Given this list of marker genes MINDY3, PLCB4, ASCC2, SPNS1, AGPAT1, SHMT1, UBE2D2, MFNG, COL9A3, TTLL10 (NCBI Gene Id 254173), RHOBTB1, TOX2, CHMP1A, PHF21B, CD2, ELMOD1, PCSK1, AMTN, ZSCAN12, NCLN, TAL1, PRR18, GPX5, DCDC2C (doublecortin domain containing 2C), CMPK2, CSRP3, DUSP6, ADGRB1, HNRNPM, DMAC2, NLE1, TCEA3, TRIM14, DPH2, ZIC3, CHIA, KIAA1191, LPCAT2, CD27, FOXC1, LGALS4, GSTO1, NFKBIB, SPAG4, NIPAL3, FRMD8, RNF25, PHYHD1, SEPTIN14, SHC2, MYH3, GATA3, EMG1, MRC1, HES6 (NCBI Gene Id 94875), FTL, AGRN, WDR55, TFF2, NYX, SLC37A2, LY86, CDHR1, HPS4, TNFRSF9, PLK3, NCF2, LAG3, TMUB2, TPSB2, ERAS, C19orf38, NLRP5, MFAP4, NPY5R, CERS2, TMPRSS13, NEDD4, EEF1E1, COL11A2, ZNF48, MED10, ETV5, TFEC, MTARC1 (NCBI Gene Id 64757), FAM3A (FAM3 metabolism regulating signaling molecule A), GATA2, ELF4, PDGFA, NLGN1, LRRC75B, ZNF653, KRTAP4-6, SLC52A2, ADAMTSL4, CD8B, DGAT1, ENG, SIX6, CRISP3, CCER1, RSAD2, AFAP1L1, XAF1, CCDC185, DHX58, PSTPIP2, ZNF654, ULK4, PGLYRP1, PPP1R37, IRAK2, FAM110B, RITA1, MAPK11, TOB2, SH3GL2, AKT1S1, PALLD, CFAP65, ALOX15B, ISCU, PMP2, GFPT2, SSUH2, SH3BP2, FMOD, RRAGD, YJEFN3, ARHGAP26, DDA1, SNX5, NFE2, MYO1D, SUSD6, MX1, GDAP1L1, RND2, ZC3H3 (NCBI Gene Id 23144), COL20A1, ARSK, CTRL, SLC27A1, TMEM30A-DT, BPIFC, NTSR2, P2RX4, MB, LYZL1, SIRT2, OTULIN, TUBA8, RND3, TXNDC2, STXBP3, MOCOS, RFX3, MUSTN1, BOC, KRT24, RGS10, EPX, TRIM59, AMHR2, KCNH7, CTNND1, KDF1 (keratinocyte differentiation factor 1), SRFBP1, KIAA1217, FAM120A, LDB3, ALG5, DAZ2, GFI1, ITGAM, SRPX2, ARAP3, SLC7A8, CIDEC, IFITM3, DPYSL3, CLEC4E, RGR, FGL1 (fibrinogen like 1), IGSF23, KIF21B, ZC3H4, KATNA1, IRAG2, ADAMTS1, MAP3K8, SIPA1, RNF166, BHLHE40, ERP27, CTSG, FBXO31, LTB4R, PPARD, HMX2, here is a description of the gene set: Human Gene Set: GSE22935_UNSTIM_VS_24H_MBOVIS_BCG_STIM_MYD88_KO_MACROPHAGE_DN from publication Qualls JE, Neale G, Smith AM, Koo MS, DeFreitas AA, Zhang H, Kaplan G, Watowich SS, Murray PJ (PMID 20716764) Nitric oxide (NO) produced by macrophages (MØs) is toxic to both host tissues and invading pathogens and its regulation is therefore essential to suppress host cytotoxicity. MØ arginase 1 (Arg1) inhibits NO production by competing with NO synthases for arginine, the common substrate of NO synthases and arginases. Two signal transduction pathways control Arg1 expression in MØs. First, a MyD88-dependent pathway induces Arg1 in intracellular infections, while a second Stat6-dependent pathway is required for Arg1 expression in alternativelyactivated MØs. We found that mycobacteria-infected MØs produce soluble factors that induce Arg1 in an autocrine-paracrine manner via Stat3. We identify these factors as IL-6, IL-10 and GCSF. We further establish that Arg1 expression is controlled by the MyD88-dependent production of IL-6, IL-10 and G-CSF rather than cell intrinsic MyD88 signaling to Arg1. Our data reveal the MyD88-dependent pathway of Arg1induction following BCG infection requires Stat3 activation and may result in the development of an immunosuppressive niche in granulomas due to the induced Arg1 production in surrounding uninfected MØs Genes down-regulated macrophages with MYD88 knockout: untreated versus 24h after M. bovis BCG infection. species: Homo sapiens